Given this list of marker genes SLC7A11, SLC25A14, FADS2, CD36, GGT7, MAPKAP1, FBLN5, SESN3, MCTP1, GCH1, BMP7, SESN1, RBX1, DHFRP1, HDAC6, PNPLA8, ABCD1, AIFM2, OXR1, MIR132, PRKN, NFE2L2 (NCBI Gene Id 4780), MACROH2A1, DHFR, PINK1, SELENON, ADCYAP1R1, SESN2, USP25, TBC1D24, MEAK7, ALOX5, KEAP1, FUT8, NCOA7, STOX1, here is a description of the gene set: Human Gene Set: GOBP_REGULATION_OF_RESPONSE_TO_OXIDATIVE_STRESS Any process that modulates the frequency, rate or extent of response to oxidative stress. studied in species Homo sapiens